Given this list of marker genes Tmod1, Lmod3, Tcap, Ttn, Myh11, Acta1, Cflar, Actc1, Plec, Prox1, here is a description of the gene set: species: Mus musculus The process whose specific outcome is the progression of the skeletal myofibril over time, from its formation to the mature structure. A skeletal myofibril is a myofibril specific to skeletal muscle cells. Mouse Gene Set: GOBP_SKELETAL_MYOFIBRIL_ASSEMBLY